The following is a description of a gene set: species: Mus musculus Any process that modulates the frequency, rate or extent of glycoprotein metabolic process. Mouse Gene Set: GOBP_REGULATION_OF_GLYCOPROTEIN_METABOLIC_PROCESS, and this is the list of marker genes: Soat1, Ctnnb1, Mgat4d, Fktn, Pomt1, Slc51b, Pxylp1, Slc2a10, Rab1a, Cst3, Aatf, Bcl2, Insr, Acot8 (acyl-CoA thioesterase 8), Ncstn, Jak3, Itm2a, Ccr7, Il33, Tcf7l2, Rab1b, Acer2, Ccdc134, Itm2b, Ep300, Ccl21a, Ago2, Hbegf, Igf1, Necab2, Necab3, Ramp1, Plcb1, Chp1, Necab1, Pomt2, Itm2c, Abca2, Abca7, Ptx3, Gata1, Mustn1, Golga2, Ccl19, Tm9sf2, Pawr, Apcs, Il15, Oga, Bace2